Given this list of marker genes Plxnb1, Apbb1, Pclo, Daam1, Igsf9 (NCBI Gene Id 93842), Ago2, Psen2, Mdga1, Etv5, Nedd4, Ssh1, Arhgap22, Dhx36, Ptpn1, Plxna4, Pdxp, Nfia, Cript, Sema3e, Dlg5, Cdh2, Sybu, Sh3gl2 (NCBI Gene Id 319329), Sdk1, Ube3b, Cdh8, Nfasc, Gsg1l, Cntnap1, P2rx2, Dok7, Cnksr2, Sparc, Cdk5r1, Arhgap39, Ptprt, Ctnnd2, Grm6, Camkv, Pgrmc1, Unc13a, Gabra6, Nlgn4l, Adgrl4, Ctnnb1, Tuba1a, Prmt3, Iqsec2 (IQ motif and Sec7 domain 2), Insyn1, Slc25a46, Rheb, Oxtr, Slc8a3, Hip1r, Dmpk, Efna1, Nptn, Unc13b, Sncg, Adgrb1, Gria1, Cdh6, Sorbs2, Gphn, Arhgap44, Slc18a3, Nckipsd, Ptprf, Ngef, Neurl1a, Sparcl1, Cdh10, Cap2, Tubb5, Hapln4, Snca, Slc1a1, Sdf4, Erbb4 (erb-b2 receptor tyrosine kinase 4), Arhgap33, Trim47, Frrs1l, Pum2, Lrfn5, C3, Cfl1, Slit2, Lgi2, Nectin1, Cd2ap, Sncb, Chmp2b, Dcx, Cntnap4, Chrd, Srgap2, Insr, Chrdl1, Filip1, Baiap2, Icam5, Ophn1, Tanc1, Vezt, Arf4, Zdhhc2, Sema3a, Egln1, Drd1, Nptx1, Plxna2, Cc2d1a, Ctnna2, Slit1, Stk38, Nlgn1, L1cam, Sema7a, Igsf9b, Oxt, Cdkl5, Afdn, Mark1, Mapk14, Fzd1, Gabrg2, Rap1b, Vps35 (VPS35 retromer complex component), Sigmar1, Zc4h2, Vangl2, Lats1, Lrrn3 (leucine rich repeat protein 3, neuronal), Flrt1, Rims3, Asic1, Cpne6, Apoe, Camk1, Kalrn, Anapc2, Palm, Fcgr2b, Rapsn, Cntn2, Slc7a11, Kirrel3 (NCBI Gene Id 72851), Nrg3, Elavl2, Prickle2, Ppfia1, Abhd17c, Pmp22, Il10ra, Nos1ap, Pdzd11, Grin2b, Zdhhc17, Ntrk3, Wasf3, Grid2 (NCBI Gene Id 94324), Ube2m, Ppfia4, Als2, Abi2, Pdgfb, Chat, Shank3, Syn1, Palld, Clstn2, Ptprs, Sptbn4, Vcp, Lrtm1, Zfp804a, Cntnap2, Lrrtm1, Dvl1, Pfn1, Lrfn1, Nedd4l, Efnb1, Pcdh8, Efnb2, Tnr, Iqsec3, Arf6, Dbn1, Mapt, Rap2a, Pcdhgc3, Adgrb2, Rapgef2, Ncan, Lrp8, Dlg2, Erc1, Rock2, Rab29, Dscam, Nbea, Elfn1, C1qa, Prkca, Il1rapl1, Large1, Dixdc1, Crtac1, Ctbp2, Farp1, C5ar1, Igsf11, Cacna2d2 (NCBI Gene Id 56808, calcium channel, voltage-dependent, alpha 2/delta subunit 2), Fgf22 (NCBI Gene Id 67112), Negr1, Gabra2, Epha3, Prnp (prion protein), Strn4, Cttn, Lrfn3, Nptxr, Lnx1, Nrp1, Tmem108, Lin7b, Lama5, Mecp2 (NCBI Gene Id 338503), Pak1, Itpka, Gabrb3, Xlr4b, Frmpd4, Gabre (gamma-aminobutyric acid (GABA) A receptor, subunit epsilon), Adgrl1, Shank2, Camk2b (NCBI Gene Id 12323), Myh10, Grin2a, Snap25, Tsc2, Fgfr1, Abhd17a, Cx3cr1, Srcin1 (NCBI Gene Id 56013), Eef2k, Itsn1, Rapgef4, Itgb3, F2r, Clasp2, Picalm, Kif5b, Ppfibp2 (PTPRF interacting protein, binding protein 2 (liprin beta 2)), Htr1a, Dock7, Igsf21, Lrrtm4, Tsc1, Gpm6a, Rest, Abl2, Eif4g1, Ins1, Sema4a, Ppfibp1, Nectin3, Grip2, Srgap3, Shank1, Mark2, Prrt1 (proline-rich transmembrane protein 1), Lrrc4c, Ube3a, Drp2, Rbmx, Rtn4, Fzd9, Ntrk2, Hdac6, Cpeb3, Adnp, Ckap5 (NCBI Gene Id 97044), Syn3, Hnrnpk, Numb, Chrna1, Ntng2, Itgam, Tnc, Gpr158, Dab2ip, Pik3r1, Ccdc39, Carmil3, Rac3, Ntng1, Chrnb2, Nrxn1, Cadm4, Tanc2, C1qb, Adgrb3, Nefl, Tenm4, Robo2, Mdga2, Dgkb, Marcks, Cbln1, Syngap1, Cbln2, Cacna1a, Dag1, Nrcam, Pcdh17, Ptk2b, Rims4, Adam10, Zdhhc12, Sort1, Kcnk13, Gap43, Tlr2, Lrrtm2, Rtn4r, Dlgap3, Sarm1, Gja10, Nae1, Ror2, Snapin, Dlg4, Slitrk4, Lrp4, Elmo1, Arf1, Caskin1, Add2, Caprin1, Ntn1, Sema4d, Mycbp2, Rab17, Arhgef7, Ephb3, Amigo2, Cbln3 (cerebellin 3 precursor protein), Dclk1, Nrp2, Psd, Slitrk2, Myo5b, S1pr2, Erbb2, Dlgap4, Slitrk5, Lmx1a, Dock10, Abi3bp, Clstn1, Rac1, Arhgef15, Arhgef9, Ptn, Cit, Rims2, Ephb1, Disc1, Sipa1l1, Slc6a1, Elfn2, Chrna7, Gnpat, Ube2v2, Igf1r, Grm5, Gripap1 (GRIP1 associated protein 1), Setd5, Synpo, Gpc4, Cdc20, Flrt3, Lrrk2, Fgf13, Col4a5, Snap91, Cyfip2, Gabrg3, Lgmn, Abhd17b, Septin7, Actn1, Mfn2, Snx27, Dtnbp1, Cdh9, 2610042L04Rik, Rab3a, Dctn1, Musk, Wasf2, Cacng2 (calcium channel, voltage-dependent, gamma subunit 2), Ptk2, Plxnb3, Nrxn3, Amigo1, Bhlhb9, Psen1, Nrn1, Cntn6, Dkk1, Iqsec1, Vstm5, Cadm1, Col4a1, Actr3, Vhl, Pls3, Thbs2 (thrombospondin 2), Lzts3, Myo9a, Lingo2, Sema3f, Cacna1s, Rhob, Magi2, Ppp1r9a, Pafah1b1, Akt1, Nrg2, Syn2, Ptprd, Gabrg1, Trem2 (triggering receptor expressed on myeloid cells 2), Wnt3a, Sez6, Hnrnpm, Ppfia2, Flrt2, Lin7c, Nedd9, Grid1, Slc30a1, Rimbp2, Septin11, Flna, Arc, Sez6l2, Ephb2, Mpp2 (membrane protein, palmitoylated 2 (MAGUK p55 subfamily member 2)), Lrtm2, Pick1 (NCBI Gene Id 18693), Caprin2, Zdhhc15, Il10, Nfatc4, Adgrf1, Stau2, Grn, Efnb3, Efna5, Spg11, Malat1, Kif2c, Pin1, Plxna3, Crkl, Gabra5, Cntn5, Wasf1, Neurod2, Numbl, Wasl, Bcan, Sdk2, Snta1, Nrxn2, Dnm3, Tiam1, Ache, Homer1, Lrfn4, Lrrc4, Akap5, Ppp1r9b, Glrb, Xlr3b, Bdnf (brain derived neurotrophic factor), Fgfr2, Lrrc24, Lamb2, Pcdhgc4, Dip2a, Gna13, Cacnb4, Ky, Gabra4, Slitrk1, Pdlim5, Kcnj8, Dgkz, Dnm1l, Tnf, Pak3, Fnta, Cask (calcium/calmodulin dependent serine protein kinase), Wnt5a, Mtmr2, Sema4c, Dock1, Rhog, Hspa8, Plxnc1, Ptpro, Ptpn13, Ywhaz, Atp2b2, Fgf7, Dact1, Fam107a, Plxnb2, Map1b (NCBI Gene Id 268696), Plxnd1, Dbnl, Lrp5, Gabra1, Wnt7b, Nedd8, Lzts1, Rer1, Cdk5, Lrit3, Plxna1, Nf1, Fzd5, Kif1a, Pfn2, C1ql2, Npas4, Nrg1, Ezr, Ghrl, Amigo3, Ina, Srpx2, Epha7, Syndig1, Slc12a5, St8sia2, Ppfia3, Opa1, Colq, Lhfpl4, Slc8a2, Pten, Ins2, Lrfn2, Robo1, Nlgn3, Prickle1, Asap1, Taok2, Abl1 (c-abl oncogene 1, non-receptor tyrosine kinase), C1ql3, Nefh, Rims1, Fyn, Epha4, Podxl, Xlr4a, Shisa6, Rph3a, Sptbn2, Cyfip1, Rock1, Klk8, Mesd, Crk, Cln3, Cacna2d3, Sdcbp, Slitrk3, Lingo4, Amot, Rab39b, Dock4, Ank3 (NCBI Gene Id 73013), Il1rap, Wnt7a, Tln2, Chrnb1, Chd4, Htr4, Afg3l2, Crmp1, Shisa7, Cux2, Lin7a, Reln, Pdzrn3, Cdc42, Il1rapl2, Sptb, Dlg1, Gabrb2, Cabp1, Get1, Stk38l, Itga3, Asic2, Cd47, Agrn, Six4, Tenm3, Bsn, Usp9x, Grin1, Plppr4, Lrrc4b, Ogt, Slitrk6, Zmynd8, Rhoa, C1qc, Tpbg, Fbxo45, Myo6, Myo5a, Sorbs1, Actr2, Dnaja3, Adgrl3, Rps6ka5, Cap1, App, Zfp365, C1ql1, Cbln4, Vldlr, Adgre5, Epha5, Gabra3, Mfn1, Ghsr, Iqgap1, Actb, Slc9a6, Lmx1b, Gsk3b, Abi3, Appl1, Lrrtm3, Dab1, Lrrn1, Actn2, Cdh1, Cttnbp2, Csmd2, Stau1 (NCBI Gene Id 99402), Gdnf, Mef2c, Sez6l, Adgrl2 (NCBI Gene Id 99633), Six1 (NCBI Gene Id 20471), Hmcn2, Itgb1, Zdhhc8, Nlgn2, Clstn3, Ntrk1, Pcdhgc5, Erc2, Drd2, Prmt8 (protein arginine N-methyltransferase 8), here is a description of the gene set: Mouse Gene Set: GOBP_SYNAPSE_ORGANIZATION A process that is carried out at the cellular level which results in the assembly, arrangement of constituent parts, or disassembly of a synapse, the junction between a neuron and a target (neuron, muscle, or secretory cell). species: Mus musculus